Given this list of marker genes CBFB, LGALS3, RUNX1, RUNX2, here is a description of the gene set: studied in species Homo sapiens Both RUNX2 and RUNX1 can stimulate transcription of the LGALS3 gene, encoding Galectin-3. Galectin 3 is expressed in myeloid progenitors and its levels increase during the maturation process (Le Marer 2000). Galectin 3 is highly expressed in pituitary tumors and glioma. Reactome Pathway: RUNX2 regulates genes involved in differentiation of myeloid cells part of: Transcriptional regulation by RUNX2